The following is a description of a gene set: Human Gene Set: PID_ARF6_PATHWAY species: Homo sapiens from publication Schaefer CF, Anthony K, Krupa S, Buchoff J, Day M, Hannay T, Buetow KH (PMID 18832364) Arf6 signaling events, and this is the list of marker genes: ADAP1, ITGA2B, GNA15 (G protein subunit alpha 15), GNA14 (G protein subunit alpha 14), CYTH2, TSHR, USP6, EFNA1, HGF, NCK1, ADRB2, IQSEC1, ACAP2, ACAP1, MET, EGF, EGFR, ITGB3, SRC, ARRB2, CYTH3, GIT1, AGTR1, KIF13B, ARF6, GNAQ, ARRB1, EPHA2, LHCGR, FBXO8, PXN, IPCEF1, GNA11, GULP1, ARAP2